The following is a description of a gene set: part of: HDR through Homologous Recombination (HRR) or Single Strand Annealing (SSA) Homology directed repair (HDR) through homologous recombination (HRR) or single strand annealing (SSA) requires extensive resection of DNA double-strand break (DSB) ends. The resection is performed in a two-step process, where the MRN complex (MRE11A:RAD50:NBN) and RBBP8 (CtIP) bound to BRCA1 initiate the resection. This step is regulated by the complex of CDK2 and CCNA (cyclin A), ensuring the initiation of HRR during S and G2 phases of the cell cycle, when sister chromatids are available. The initial resection is also regulated by ATM-mediated phosphorylation of RBBP8 and CHEK2-mediated phosphorylation of BRCA1. After the initial resection, DNA nucleases EXO1 and/or DNA2 perform long-range resection, which is facilitated by DNA helicases BLM or WRN, as well as BRIP1 (BACH1). The resulting long 3'-ssDNA overhangs are coated by the RPA heterotrimers (RPA1:RPA2:RPA3), which recruit ATR:ATRIP complexes to DNA DSBs and, in collaboration with RAD17:RFC and RAD9:HUS1:RAD1 complexes, and TOPBP1 and RHNO1, activate ATR signaling. Activated ATR phosphorylates RPA2 and activates CHEK1, both of which are necessary prerequisites for the subsequent steps in HRR and SSA. species: Homo sapiens Reactome Pathway: Processing of DNA double-strand break ends, and this is the list of marker genes: UBE2I, DNA2, HUS1, RFC3, CLSPN, BRIP1, H2BC17, H2AX, BRCA1, ATRIP, CDK2, UBE2V2, RNF8, WRN, RFC5, RAD50, RPA2, TP53BP1, NSD2, ATR, PPP4C (protein phosphatase 4 catalytic subunit), BLM, H4C1, BABAM1, HERC2, H2BC9, H2BC21, UBB, H2BC12L, RPA1, H2BC26, MDC1, RBBP8 (RB binding protein 8, endonuclease), BARD1, H2BC3, H2BC4, RPA3, RMI2, RFC2, H2BC5, RMI1, RHNO1, EXO1, TOPBP1, ATM, ABRAXAS1, RAD1, H3-4, NBN, RNF168, TOP3A, KAT5, CCNA1, H2BC13, CCNA2, CHEK1, UBC, BRCC3, SUMO2 (NCBI Gene Id 6613), PIAS4, MRE11, RNF4, RAD17, TIMELESS, RAD9A, H2BC14, PPP4R2, H2BC1, RAD9B, UBE2N, H2BC12, H2BC15, TIPIN, RFC4, UBA52, RPS27A, SIRT6, BABAM2, H2BC11, UIMC1